Given this list of marker genes NR1H4 (NCBI Gene Id 9971), MALRD1, CES1, KIT, SIRT1, CYP7A1, ABCB11, PROX1, FGFR4, STAR, FGF19 (NCBI Gene Id 9965), PANK2, NR1D1, STARD4, MIR33A, here is a description of the gene set: Human Gene Set: GOBP_REGULATION_OF_BILE_ACID_METABOLIC_PROCESS species: Homo sapiens Any process that modulates the frequency, rate or extent of bile acid metabolic process.